Given this list of marker genes Mylk2, Scn4a, Myh7, Dmpk, Actn3, Prkd1, Atp2a1, Casq1, Dmd, Rem1, Kcnj2, Slc8a3, Grcc10, Cav3, Kbtbd13, Nr4a1, Strit1, here is a description of the gene set: species: Mus musculus Mouse Gene Set: GOBP_REGULATION_OF_SKELETAL_MUSCLE_CONTRACTION Any process that modulates the frequency, rate or extent of skeletal muscle contraction.